Given this list of marker genes TXLNG, ZBTB26, DNAJC18, RAD18 (RAD18 E3 ubiquitin protein ligase), OGN, KNG1, SMAP1, ESRP1, SEMA3A, GDF6, SDE2, LZTS3, MDM2, FZD4, PLEKHG2, SMAD9, NR6A1, VGLL3, FAM76A, MCTP2, TMLHE, SGPP1, UBE2E3, CFAP300, MAP3K2, CXCL11, MTMR2 (myotubularin related protein 2), NRARP (NOTCH regulated ankyrin repeat protein), ZCCHC2 (NCBI Gene Id 84810), NHLRC3, TNRC6B, GALNT15, TLCD2 (TLC domain containing 2), DNAJC30, LINGO2, MTO1, ZNF582 (NCBI Gene Id 147948), EIF4G2, PEX11B, RAB30, PITPNM3, CCDC88A, ELMOD2, METTL4, PPP4R1, here is a description of the gene set: from publication Chen Y, Wang X (PMID 31504780) Genes predicted to be targets of miRBase v22 microRNA hsa-miR-379-5p in miRDB v6.0 with MirTarget v4 prediction scores > 80 (high confidence targets). Human Gene Set: MIR379_5P studied in species Homo sapiens